Given this list of marker genes LNP1, SCAND3, MRPL9, ARL6IP6, MRPL46, MKRN1, CROCCP2, POGZ, RANBP17, GGA2, EEFSEC, NECAB1, DPYS, RUSF1, EXD3, RO60, PLXDC2, MGAT2, AGTPBP1, FBXW8, YIPF4, FBXO43, MRPS31, PYCR2, ZNF354B, PTBP3, C3orf38, LACTB2-AS1, RFESD, HHAT, NDUFV3, OPRD1, BEX1, DARS1, FITM2, CAPRIN2, AP4E1, DBF4B, PGBD5, DDHD2, TOMM40P3, TMEM50B, SUPT7L (NCBI Gene Id 9913), LRRN2, ISL1-DT, EOGT, CTSL3P, BRAF, LTV1, ZNF783, MITD1, CHID1, YTHDC1, MTRES1, MED14OS, SYT14, GASK1A, N4BP3 (NCBI Gene Id 23138), ENSG00000213963, PABPC1L, PABPC5, NIPAL1, DNAJC6, MKRN2, CACNG5, LNCRNA-IUR, WASF2, WDR41, ALG3, PIGQ, RASSF8-AS1, PANK2, PARP10 (NCBI Gene Id 84875), DHX40, SSBP4, COL6A4P1, DPAGT1, SOS1, NELFA, DNAJB11, PAFAH2, DCBLD2, SPOUT1, HMGB1P25, PDCD2L, PIAS1, ZFP30, EPHA1, ATP8B2, WWP1P1, TPM1, TMEM169, FAM136CP, GLT8D2, EIF3FP1, ATP1B1, RMDN2 (regulator of microtubule dynamics 2), ACSL4, CATSPER2P1, ST3GAL6-AS1, PHTF1, ABT1, SGK3 (serum/glucocorticoid regulated kinase family member 3), ARHGEF4, MECP2, MAD2L1-DT, LYPLAL1-DT, GOSR2-DT, TRIM7, LYNX1, B4GALNT2, APIP, NFIA, MED15, CYB561D1, SLC39A6, NEPRO-AS1, PALM2AKAP2, PIBF1, VPS33A, NEMF, MED23, GFM1, LINC02564, MELTF, KAT6A, RUSF1-DT, POLE2, NOXA1, ZFAND4, HCFC2, TRMO, NAP1L2, RAB4A-AS1, ARL8BP2, BORCS5, JMJD1C, MTCO3P12, THYN1, GRINA, LRRC34, NFASC, UBN2 (ubinuclein 2), BABAM2, PRKCA, ENSG00000267024, VIM, MED14, ROBO2, HSPBAP1, STARP1, SGMS1, KALRN, BEX3, GMCL2, ZNF24, AKAP1-DT, TPMT, MCL1, UBQLN1-AS1, TCERG1, MAN1B1, MCTP2, GPRASP2, LEPR, KDM3A, MARCHF5, NT5DC1, SLC35B4, PEX2, LARP6, AADAT, AGPAT3, TOPAZ1, RAB40A, ERN1, SLC10A3, SP3, RGS12, SLC25A28, LRRC15, ENSG00000228021, RAB9B, SORCS1, LIPT2-AS1, ZMPSTE24, APCDD1L-DT, CLPTM1, GBA1, STK24P1, LINC01968, ADGRG4, SLC36A4, GRAMD1C, ZMYM4, PALS2, PDE3A, CLTC, SLC5A7 (solute carrier family 5 member 7), ANGPTL6, LINC02980, ELP2 (elongator acetyltransferase complex subunit 2), M1AP, SSB, MESTP1 (mesoderm specific transcript pseudogene 1), ALDH4A1, SENP8, RFKP1, SESTD1, ZNF35 (NCBI Gene Id 7584), PDE8A, AKAP1, CDH18-AS1, SPIN2A, KEAP1 (kelch like ECH associated protein 1), MT-TF, CNOT6, XBP1, RPL37, FAR1 (fatty acyl-CoA reductase 1), TFG, MAP3K7CL, HERC6, ZNF271P, EMBP1, FMNL3, SYPL2, LRRC49, PANK2-AS1, MAPKAPK5, FGF13, P4HA3-AS1, PREP, SATB1, ZNF585B, RTTN, SPO11, BBX, ABL2, MRPL40, HAPLN1, MIR5191, CLDN1, ATP13A1, MARK4, FERMT1, GDAP2, UBXN4, SNX24, PGAM1P4, MORC2, ARRDC3 (arrestin domain containing 3), MOSPD3, NPY2R-AS1, NUDCD3, TMEM167B-DT, WDTC1-DT, DYNC1LI1, MARVELD2, POLR1H (RNA polymerase I subunit H), TRDMT1, MIR3613, FA2H, RGMB-AS1 (RGMB antisense RNA 1), PLEKHF2, CCDC148, MYSM1, PAICS, TMEM109-DT, UBE2Z, FAM222B, FYCO1, FBXO22, LIN9, CBLB, SPATA18, P3H2-AS1, ARHGAP44, NEPRO, SPATA2, MTR, ARFGEF3, ZBTB38, HTR2C, DPY19L2P3, PHACTR1, CAMK4, XAGE3, RPRD1A, TATDN3, PELP1-DT, CPSF7, SMARCC2, HS3ST5, TEX35, TOR1B, PPP1R8, NAXE, ZDHHC15, H2BP9, SEC62, ZNF362, TMEM39A, TNFSF14, RSPO3, PPP1R42, SNX7-DT, LMBR1, FLVCR1, SERINC5, PM20D2, ATRN, SMG7-AS1, FUOM, PPIL4, MYCBP2-AS1, BAZ2B, ZNF2, STK31, POU2AF1, TMEM19, CEP63, HEY1, ARHGAP36, B4GALT7, SNAP25-AS1, TOP3B, KIRREL3, SLC4A1AP, MEF2A, GOT2, STARD10, ACOT12 (acyl-CoA thioesterase 12), DPYD, RNA5SP21, AP1M1, CYB5R4 (cytochrome b5 reductase 4), EHD3, CPNE8, LINC00466, PLLPP1, GATAD2A, ST3GAL6, IL17RD, RC3H1-DT, CIBAR1-DT, SYTL4, CARTPT, HUS1B, CHSY1, ZNF654, ZNF292, CLOCK, ASCC2, TMEM230, RBKS, DDX21, CFL2, DCLK3, ACOT13, TAF9, MYO19, WDR82P1, IQCH-AS1, TMEM260, SMAD5, REXO2, PPP2R2B, NDFIP2 (NCBI Gene Id 54602), NHLRC2, ADAM9, CELF2, LCN8, CRYZ, IGHA2, KIF3A, UBE2H-DT, HOXD8, THBS3-AS1, DOCK11, UHMK1, MT-RNR1, ATP1A1, NEMP2-DT, SGIP1, MAGEF1, SLC25A51, CDC42BPA, PCCA-DT, ACSF3, MAP3K3 (mitogen-activated protein kinase kinase kinase 3), PGBD4, CEP95, COCH, GOLGB1, FRG1FP, NUCB2, MND1, DMAP1, AK6, DPH5, CD83, LRBA, SSBP3P1, WTAP, CLK3 (CDC like kinase 3), FAAH, MINPP1, HNRNPD, HSP90AA1, ATP5PB, RNVU1-14, PRF1, HYLS1, NDUFAF4, KATNBL1, FAM9C, RASSF8, FAM161B, HLCS, SESN3, KCNJ2, CYBC1, CAPN12, MIR1258, TRPM3, BMI1, BLOC1S6, MRPS30-DT, RGS6, RAD1, CDKL3, TBC1D7, LINC02371, DDX41, VTI1A, CASP9, ZNRF2P2, OGT, ADAMTSL4, NSL1, SGO2, LRRC8B, LINC01182, MIR5087, ZNF329, LINC01285, GNB4, UGGT1, CNBD2, SF1, CLASP2, OPRM1, AMOT, SLC25A28-DT, PCP4L1, AUTS2, STK32A-AS1, CPEB3, LRRC27, GSTA4, HACD3 (NCBI Gene Id 95112), RFK, ANK3-DT, RBM45, WASH3P, SELENOH, EIF5A, NAV1, PARP9, KCNAB1, MAPDA, ENSG00000232732, HSF5, USP13, TMC5, TTC7A, PTGES3P3, PFKFB2, ZBTB34, USP17L23, MAP2, FBXO10, ABCG1, KCNMB4, RFKP5, BTNL12P, MAN1A2, DIXDC1, PSMB1, PDCD2, SMIM26, GUSBP18, EPAS1, ENSG00000278899, SMARCD2, PIDD1, EIF2D, NSMCE4A, CBX1P3, ZKSCAN2-DT, FOXJ3, ADISSP, SKIDA1, LMNA, WDR77, RP9, KATNAL1, PELP1, EMC7, LINC01201, NDUFS7, SETMAR (NCBI Gene Id 6419), RTL8C, C2orf68, STX18-AS1, LAD1, LINC01023, EVI5 (NCBI Gene Id 7813), CHD1-DT, SWAP70, RHBDD1, NLRC5, CPLX1, TDRD7, ODR4, SNORA13, PLCD3, RAG1 (NCBI Gene Id 5896), LINC00879, SUSD5, TMEM41A, NUP133-DT, RHOV, CCDC88A, DCTN5, NUB1 (negative regulator of ubiquitin like proteins 1), RN7SK, DLAT, CYB5A, EPB41L4A-AS1, C8orf76, MEGF10, ZC3H14, MARCHF8, PIGP, ABCD3, VIPR2, SF1-DT, ZNF518A, TEAD1, TMEM266, WDPCP, BZW1-AS1, RBM26-AS1, PTPRB, EPB41 (erythrocyte membrane protein band 4.1), NRBP1, GBX1, IGDCC3, ABCC11, ECE2, TP73-AS3, TAF4B, CYP4F23P, FAM91A1 (NCBI Gene Id 157769), KIF18B-DT, ENSG00000233030, MORF4L2-AS1, CCDC57, SMG9, KIF16B, MED15P9, STX16, BICD1, NPFFR1, ENSG00000255647, SRSF7, PRDX6 (peroxiredoxin 6), GOLGA3, TBXA2R, TRIM14, MCCC1, NDUFAF6, USF2, NRG4, SSU72, HTATSF1, YWHAG, ZBED9-AS1, TBC1D8, ATG4C, C14orf39, BZW1, KLC2, PDGFD, STK32A, NMNAT1, GJC1, UBE2H, SRPRB, NKAIN3, ARID1B, SUV39H2, COX8C, RTRAF, RFKP6, AGTR1, HEG1, FAM174A-DT, ARMC8, NRIP1, NPL, DBR1, RNVU1-21, CETN3, HK3, NOX5, ARL6IP1, RHEB, HELZ2, MFSD9, SDE2, PHF24, COX20, TMT1B, SPACA1, CALHM6, COQ6, LAMTOR5-AS1, TUBB4BP7, DHRS7, ZNF280B, MBOAT2, MIR4634, NORAD, ELOA-AS1, H2BC26, TMEM178B, NDUFA12, SLC35A1, UBQLN1, TMEM114, NMUR1, MCM9, SFXN1, PFKFB4, GLUD1P3, C14orf132, ERVK3-1, STK32C, PLEKHA8, AHNAK, DPH5-DT, DESI2, POTEA, CARINH, MDH1, SYT9, S100A1, CBFB (NCBI Gene Id 9163), PLD1 (phospholipase D1), SNUPN, RPL36P6, MGLL, SNORA26, ARHGEF12, RYR2, HIRA, APCDD1L, SPDL1, PHIP, GALNT16-AS1, PPP2R5A, DANCR, EIF4A1, DUSP16 (NCBI Gene Id 80824), SNORD45C, COL6A4P2, GRK3-AS1, FAM242C, PSD4 (NCBI Gene Id 23550), MIR4449, PPP1R2P10, EIF2AK1, ABLIM3, ASB3, ZDHHC23, CDC14B, ZBED6, MTERF4, LAMA4, MRPL39 (mitochondrial ribosomal protein L39), SEPTIN8, LIFR-AS1, GMPR, USP30, CCNG2, BUB3, PA2G4, NUF2, LINC00331, RPL26, NRBF2P5, VPS36, SETD2, NKAPL, MBL1P, TM9SF3, ZKSCAN2, MIR4500HG, RPS21-DT, MTF2, ODF2L, EEF1E1, RBMXL2, PDE6D, GPRASP1, PGAM1P10, SLC35F1 (NCBI Gene Id 222553), QRICH1, KCTD5P1, UBE2D3, COMMD6, ZBTB18 (NCBI Gene Id 10472), WDR35-DT (WDR35 divergent transcript), LONP2, PRP4K, FAM181B, UNC5C, LINC01902, ZNF280D, INTS13, CASP6, KCNJ2-AS1, ACTN1, IDS, FANCI, CCDC22, FAR1-IT1, DDX5, RAET1M (retinoic acid early transcript 1M (pseudogene)), TTC23L-AS1 (NCBI Gene Id 101929704), EPM2A-DT, KRT18P43, RNF38, H3C6, RHOBTB3, GSTM4 (glutathione S-transferase mu 4), ANKRD13C, TFAP2A, ADPRH, SLCO4C1, BMS1P4-AGAP5, CABCOCO1, MPC2, ZSWIM4, TPD52L1, PPA2, CKS1B, PCBD2, MAGI1, H2AC25, SAR1B, MAGI2, CELSR1P1 (CELSR1 pseudogene 1), LAMTOR5 (late endosomal/lysosomal adaptor, MAPK and MTOR activator 5), LDLR, SLC35G1, CYP2J2, STX8, POLD3, NME9, CTNNA2, EZH2, MPLKIP, UPF3B, SF3A3, NAAA, SLC4A10, EOGT-DT, CINP, GUK1, CCDC181, AGBL4 (AGBL carboxypeptidase 4), ZBTB20, TIMM8A, DMXL1-DT, SUGCT, LARP7P4, CENPP, RNA5S17, SLC24A1, GSK3B-DT, THTPA (NCBI Gene Id 79178), CAVIN2-AS1, FMR1-AS1, ZDHHC4, ZFP62 (NCBI Gene Id 92379), USP24, HAND2, COX5A, CTLA4, WDR20, ENSG00000233656, CHKA, MTHFD1L, RNF150, CAND2 (cullin associated and neddylation dissociated 2 (putative)), COPS7B, BOLA2P3, UST-AS2, MAML1, STUM, RHOT2, LNCARSR, NOL8, CLDND1, TBC1D14 (TBC1 domain family member 14), RAD17, LINC00358, UCP2, NAP1L3, TMEM101, SDHAF2, NUDT16-DT, MIR4258, SRR, SLC13A3, SMIM10L1, UCHL5, CCNYL5, MYO1B, KCNH1, VCP, CARNMT1-AS1, RPS2P2, SNCAIP, DPYSL3, NDUFC2-KCTD14, UHRF2, EFCAB6-AS1, CLDN16, ADNP, WTIP, ZNF100, LDHC, AFG2A, SYMPK, ENPP3, SRSF11, PHF21A, RASAL2-AS1, PELO-AS1, SLC20A2, CDIPT (CDP-diacylglycerol--inositol 3-phosphatidyltransferase), RSAD1, TIGD6, CDCA7L, ZNF514, CNTNAP2, BRI3P2, CCDC121P1, PARP8, ZNF345, C4orf36, SRSF10, EXOSC3, CPE, VPS72, PTAR1 (NCBI Gene Id 375743), ZFP1, TPCN1, DGAT2-DT, SFT2D2, PSMF1, RBFOX2, RPL36AL, ERICH3, SSTR3, ELK2BP, FAM107A, LETR1, SANBR, NPY2R, MIA3, DNAJB1, CARNMT1, C11orf54, SNHG5, CTH, NBN, DND1P1, NFE2L2, DPY19L4, DDHD1-DT, SRSF8, LOH12CR2, RBM26, ATP5ME, PRR4, MAGI2-AS3, POP4, TTC14, INO80C, NUMB, SYT16, DCTN1, PRR14L, EEF1AKMT1, BATF3, FILIP1L, PIP5K1B, RHOF, MGAT4A, MAP4K5, ANKRD40, FIRRM, DCP1A, H2BC15, PCDH9, XIAP, ARRDC3-AS1, ACOT11, GLS, PTPN14, POLR1HASP, LINC01683, USP4, PPM1L, UCHL3, NET1, ZHX3, SMIM10, HMCN1, PDIA3, PPM1K-DT, ECT2, S100A13, STK17B, ERICH2-DT, SYNGR3, NT5C3B, SRD5A1P1, POTEH, MORF4L1, FYN, SNHG11, SPCS2, COG5, ACADS, BTF3L4, HAGLR, THAP10, CHD1, NUDT6, LINC02684, FAM241B, ATP5MC1, CCNYL6, MST1L, TMEM31, KCNH1-IT1, ENSG00000232995 (NCBI Gene Id 127814295), PARLP2, INTS14, MRPL44, SRP9, KCTD5, PIP4K2C, POGLUT3, CCDC175, CNBP, CRIPT, ANP32BP3, VCF2, GSTO1, PFN1P1, XKR8, TBCA, RALA, GPR89P, DCLRE1A, VPS33B-DT, LSR, NR1H2, SCML2, ITGA9-AS1, LEFTY3P (NCBI Gene Id 286754), SCN5A, BOK-AS1, BAIAP2L2, EHMT1, GRB2, FUS, ALKBH3, RPAP2, RBBP7, JAGN1, LAPTM4BP1, PDCD6IP, JPX, TVP23B, WDR35, LIPT2, ZFHX2, NAIF1, SAP30-DT, PPAT, UBE2B, SFTPB, PABPC5-AS1, ABCA7, CTDNEP1P2, DEPDC1, MOGAT1, JKAMP, ZNF391, C2CD2L, XRRA1, DTWD2, PDP1, BANK1, TASOR, COX11P1, PLS1, CHIC2, MIR378D2HG, CACYBP, TRAPPC2, TYW3, EFCAB10, WDR4, STAG2, CACHD1, B3GALNT2 (NCBI Gene Id 148789), ANKRD29, CPVL, PARP3, MBTD1, HADH, CCNL1, CDIPTOSP, HOXA4, RABGGTB, GCLM, PPM1K, SMIM19, IKZF1, PRTN3, FMC1-LUC7L2, GEMIN7, CHRM1, CKAP5, BCL3, RUVBL1, PPM1L-DT, RALYL, SLC16A6, FNBP1L, RTL8A, CGGBP1 (NCBI Gene Id 8545), STX6, SYT6, ZNF706, DMXL1, NDUFC2, FMR1, RC3H1, MCRIP2, BBS9, LINC01703, ANK3, CDKL5, TTC23L, FAM120C, UBE2D3-AS1, LZIC, USP37, EIF1B-AS1, RPS10P29, TMEM183A, CTDSPL, FBN1, RGS5, GALNT1, TYW5, SLC16A1 (solute carrier family 16 member 1), MTNR1A, MYO9A, UQCC6, PHC2-AS1, VEZT, NR0B1, MFSD14A, GAS2, ANKRD20A21P, ZNF383, HMGN4, SLC7A5P1, NEMP2, CNPPD1, FTCDNL1, BTBD1, ALOX15, KRTAP13-5P, OXCT1-AS1, OCRL, MRPL58, CDC73, SPECC1L-ADORA2A, GAPVD1, ZNF767P, WDR3, ANKRD13C-DT, NKAIN2, ANAPC13, HRK, DLEC1P1 (NCBI Gene Id 100421153), NSMAF, NMNAT3, GTF3C3, DDX17, L3MBTL4, SNORD50B, SUB1, SLC16A1-AS1, SSU72P1, PALB2, FGD6, GNE, ETFA, SLC35A3, PRSS42P, CCNB2, TTC14-DT, MNT, SLC35E4, B4GALT6, TMX4, EXD2, TOB2, GYG1P2, MRPL30, ITGAE, TAF12-DT, ATL1, ASB7, CHGB, CHASERR, PECR, SMIM10L2A, TBK1, RAPGEF1, STX16-NPEPL1, SUFU (SUFU negative regulator of hedgehog signaling), TP53BP2, DSC2, BRWD1 (NCBI Gene Id 54146), ZNF57, PIGW, WDR27, LINC00467, ELL2P3, ATXN1-AS1, MOB1B, SNX2, C1QBPP2, MCM3AP-AS1, YAP1P2, RCOR3, ANKRD31, ZNF790, ATP2B2, RRAGAP1-AS1, AFF3, ZFTA, LINC02750, TM2D2, CARD11-AS1, SASS6, UPF1, IFNA2, NOL4, RAD51D, LCORL, DDHD1, PSEN2, VPS37B, C15orf61, GSK3B, ARHGEF11, AQR, CIBAR1, NSFL1C, PPP1R14BP5, HNRNPD-DT (HNRNPD divergent transcript), DENND1B (DENN domain containing 1B), MIGA1, FGFR1OP2, KIAA1328, CREBBP, C1orf53, LINC02709, DNTTIP2 (deoxynucleotidyltransferase terminal interacting protein 2), ARMCX3-AS1, RBBP5, PAFAH1B1, FAM237B, THAP12P3, YWHAZ, SLC25A3P1, CCDC25, NENF, CCDC18-AS1, MIR933, COL21A1, SFSWAP (NCBI Gene Id 6433), GRK6, MON2, USP39, HOXA9, EML1, MIR137HG, FAF2, ZDHHC13 (zinc finger DHHC-type palmitoyltransferase 13), MAIP1, ADAR, TBL3 (transducin beta like 3), TSEN15, EIF3D, TBCCD1, TMEM167B, SPECC1L, ZDHHC6, PRPF40A, STK24-AS1, AGO4 (argonaute RISC component 4), ENSG00000215156, BRIX1, ALDOA, NTRK2, AP3M2, L1TD1, EXOSC7, NPHP3, DCAF12L1, PRDM4, GLMN, CCDC178, KRT18P32, IQCD, AMMECR1, MCC, LRP3, CABYR, SMG7, C1GALT1C1, IPO4, UBA2, TLE4, TACO1, ACER2, CTNS, RETREG2, ADAMTSL5, TMBIM6, RNF14, ZNRF2, SSU72-AS1, RTBDN, LINC01972, SNX25P1, FLVCR1-DT, MBNL1, COQ8A, ST8SIA2, MRPS30, TRBV9, ZCCHC7, DHX9, SLC44A1, PGK1, EIF4A2, HMGXB3, SBF2, PRRG4, RNA5SP283, FOXP2, PITHD1, HFM1, H1-4, CHN2, ACSL3, PRKXP1, SLC39A11, OAZ2, OFD1, ZSCAN30, KIF9-AS1 (NCBI Gene Id 285352), KBTBD12, CAPN15, ADAMTS7P3, NOM1 (nucleolar protein with MIF4G domain 1), HNRNPU, RRP9, ENSG00000263280, ANXA11, BUD13, PRPH, GALNT10, ENO1P1, ROR1, DRG1, CCM2L, C2orf42, GALNT2, EPB41L4A, PADI2, JOSD1, DTD1, BUD13-DT, OLIG1, KSR1P1, ID4, VHL, PSTK, DUS4L (dihydrouridine synthase 4 like), GVQW3, CBR3-AS1, SGSM3, RCAN1, NAGLU, TXNDC12, CYP2S1, RPS21, NEK11, MORF4L2, NDFIP2-AS1, MAPKAPK5-AS1, ANKRD13D, PCYOX1, STARD4, DNAJC28, ENSG00000237378, IL6ST-DT, TARDBP, ANKRD50, LARP4, TMX4-AS1, EPB41L2, METTL5, ZNF644, ENSG00000267053, SKIL, TRMT13, CRYBG1, GK5, CPD, VLDLR-AS1, TRAM1, ITGB2-AS1, UBE2N, CHKA-DT, KDM1B, SNX7, ZMPSTE24-DT, THAP12P8, SLC37A3, YWHAB (tyrosine 3-monooxygenase/tryptophan 5-monooxygenase activation protein beta, NCBI Gene Id 7529), PDE4D, OAZ3, NDNF, PDHX, FHL1P1, PAM, FBN1-DT, TIPARP, PANK3, ST6GALNAC3, BNIP1, TMEM14A, ASTE1, IL6ST, DACT3-AS1, RAB11A, STK24, PHACTR2, MYCBP2, PPP1R12A, LIN52, H2AC15, DCAF8, TAOK2, SYNE1, LINC03047, MIR3190 (microRNA 3190), SRI, SUN1, GML, YOD1, L3HYPDH, CD55, MAPK1, ZC4H2, SLC17A3, AKAP7, BRINP3, LINC02716, STX18, ASS1, ISL1, BMS1P4, TAF1D, KIF14, RNFT1-DT, BMP6, USP33, AP4S1, RFKP3, AMZ2P1, TRPC3, LINC02746 (long intergenic non-protein coding RNA 2746), FUT8-AS1, MFNG, FAM169A, CHD7, LYPLAL1, FAM86HP, C10orf53, PLSCR1, CTBS, GEMIN6, RSPH3, ZNF518B, HSPB1P2, ADGRL1-AS1, DIP2A, NPHP3-ACAD11, PKP4, BRINP3-DT, AGPS, DNAJC16, ITGA2, GORASP2, CLPP, NUP54, ALDH5A1, BAZ1A-AS1, ZNF527 (zinc finger protein 527), PHC2, MED18, CNGA1, FOXI1, SNRNP25, ACTR3B, POLR3K, ENSG00000227355, CMSS1, HTR5A, EIF1B, PTP4A2, GPAM, ACAD8, NCK1-DT, MBD3, LINS1 (lines homolog 1), SLIT3, HMGCR, BRI3P1, SLC6A15, CDC25B, LINC00485, ARSG, LINC00664, MRPS11, DERL3, PLCXD2, SRD5A3, TPGS2, FAM133A, TMEM64, DENND2B, PTPRU (protein tyrosine phosphatase receptor type U), CAPN14, KXD1, LINC01596, RNU6-587P, ZNF621, SPATS2L (NCBI Gene Id 26010), here is a description of the gene set: Genes containing one or more binding sites for (ZNF618) in their promoter regions (TSS -1000,+100 bp) as identified by GTRD version 20.06 ChIP-seq harmonization. Human Gene Set: ZNF618_TARGET_GENES from publication Yevshin I, Sharipov R, Kolmykov S, Kondrakhin Y, Kolpakov F (PMID 30445619) studied in species Homo sapiens